Given this list of marker genes PPP1R12BP1, TMEM158, ENSG00000272668, FAM171A2, POU3F2, STMN1, ZNF883, DPY19L2P4, LRRIQ4, MTCO1P19, SCG5-AS1, TMPRSS7, CAMKV, ZBTB11, ADAM32, FBXL19, FABP7, RNU6ATAC42P, RAB4B-EGLN2, NEUROD2, ANO8, GPRIN1, ABCG4, TANK-AS1, FNDC4, RNY4P19, ANKRD62P1-PARP4P3, ZBTB24-DT, BCL6, RASL10A, POU3F3, RN7SL735P, LINC00115, NUP93-DT, KIF3C, EEF1DP7, INHBE, ARHGAP33, LINC02942, LCORLP1, FCF1P1, SP9, ZNF746, PCDHGA10, CCDC77, FABP5P3, SUSD5, RN7SL481P, ZBTB18, ADGRB2, SLC22A2, SLC19A4P, LAMB2P1, ABHD8, HAPLN2 (hyaluronan and proteoglycan link protein 2), NEUROD6, PHC1, UBQLNL, PPP1R14BP3, ADGRL3-AS1, ZNF567-DT, PI4KAP2, HCRT, GNG8, ATF7-NPFF, ENSG00000231460, DHPS, CPVL-AS1 (NCBI Gene Id 107986703), GCSIR, SLC14A2-AS1, PTPRD-AS1, NPY5R, WASL-DT, SLC7A10, SPRN, SF1-DT, LINC01498, THSD4-AS1, B4GALNT4, LINC02306, SATB2-AS1, MIR600HG, LPAR2, LRRC37A11P, PANX2, RPS10P13, PCDHA11, CDK5R1, GPR158-AS1 (GPR158 antisense RNA 1), LINC01081, RPS25P3, LINC00710, TRPV1, ENSG00000248837, JMJD7-PLA2G4B, THNSL1, ZFP37, LINC02933, MUPP, ENSG00000259118, NFIX, SEPTIN3, SBK1, GLIS2-AS1, LINC01923, WASF1, PPP1R12A-AS1, TTC21B-AS1, AFDN-DT (AFDN divergent transcript), RAB3A, CSRP2, SRM, TAF7L, NYAP1, PNLDC1 (NCBI Gene Id 154197), RPS11P5, RFPL1S, FOXG1, RPL23AP82, DOHH, LINC02699, VPS26B, DUSP5P1, RBISP5, TRAPPC5, EFL1P1, LMTK3, PROKR2 (NCBI Gene Id 3733), RPL21P118, HYI-AS1, ENSG00000187186, ALOXE3, CDKL2, PCDHGB8P, GSX1, JAZF1-AS1, NXPH3, GOLGA7B, SCUBE1, GGN, TMEM240, KLF3P1 (KLF3 pseudogene 1), HPF1, B3GAT1, CATSPER3, MRAP-AS1, ARL10, MCRIP1, PKD1, RPL32P16, IL11 (NCBI Gene Id 3589), FAM220A, here is a description of the gene set: The gene expression program underlying the specification of human cell types is of fundamental interest. The study authors generated human cell atlases of gene expression and chromatin accessibility in fetal tissues. For gene expression, the study authors applied three-level combinatorial indexing to >110 samples representing 15 organs, ultimately profiling ~4 million single cells. The study authors leveraged the literature and other atlases to identify and annotate hundreds of cell types and subtypes, both within and across tissues. Our analyses focused on organ-specific specializations of broadly distributed cell types (such as blood, endothelial, and epithelial), sites of fetal erythropoiesis (which notably included the adrenal gland), and integration with mouse developmental atlases (such as conserved specification of blood cells). These data represent a rich resource for the exploration of in vivo human gene expression in diverse tissues and cell types. Marker genes curated from the annotated cluster as represented in the Descartes Human Gene Expression During Development database. species: Homo sapiens Human Gene Set: DESCARTES_MAIN_FETAL_SATB2_LRRC7_POSITIVE_CELLS from publication Cao J, O'Day DR, Pliner HA, Kingsley PD, Deng M, Daza RM, Zager MA, Aldinger KA, Blecher-Gonen R, Zhang F, Spielmann M, Palis J, Doherty D, Steemers FJ, Glass IA, Trapnell C, Shendure J (PMID 33184181)